Given this list of marker genes CYP1B1, AKR1A1, EPHX1, AKR1C2, CYP3A4, CYP1A1, AKR1C4, AKR1C3, AKR1C1, here is a description of the gene set: studied in species Homo sapiens Human Gene Set: WP_BENZOAPYRENE_METABOLISM Benzo(a)pyrene metabolism